The following is a description of a gene set: studied in species Homo sapiens Human Gene Set: GSE21033_1H_VS_12H_POLYIC_STIM_DC_UP BACKGROUND: Dendritic cells (DC) play a central role in primary immune responses and become potent stimulators of the adaptive immune response after undergoing the critical process of maturation. Understanding the dynamics of DC maturation would provide key insights into this important process. Time course microarray experiments can provide unique insights into DC maturation dynamics. Replicate experiments are necessary to address the issues of experimental and biological variability. Statistical methods and averaging are often used to identify significant signals. Here a novel strategy for filtering of replicate time course microarray data, which identifies consistent signals between the replicates, is presented and applied to a DC time course microarray experiment. RESULTS: The temporal dynamics of DC maturation were studied by stimulating DC with poly(I:C) and following gene expression at 5 time points from 1 to 24 hours. The novel filtering strategy uses standard statistical and fold change techniques, along with the consistency of replicate temporal profiles, to identify those differentially expressed genes that were consistent in two biological replicate experiments. To address the issue of cluster reproducibility a consensus clustering method, which identifies clusters of genes whose expression varies consistently between replicates, was also developed and applied. Analysis of the resulting clusters revealed many known and novel characteristics of DC maturation, such as the up-regulation of specific immune response pathways. Intriguingly, more genes were down-regulated than up-regulated. Results identify a more comprehensive program of down-regulation, including many genes involved in protein synthesis, metabolism, and housekeeping needed for maintenance of cellular integrity and metabolism. CONCLUSIONS: The new filtering strategy emphasizes the importance of consistent and reproducible results when analyzing microarray data and utilizes consistency between replicate experiments as a criterion in both feature selection and clustering, without averaging or otherwise combining replicate data. Observation of a significant down-regulation program during DC maturation indicates that DC are preparing for cell death and provides a path to better understand the process. This new filtering strategy can be adapted for use in analyzing other large-scale time course data sets with replicates. Genes up-regulated in bone marrow-derived dendritic cellstreated by poly(IC): 1h versus 12h. from publication Olex AL, Hiltbold EM, Leng X, Fetrow JS (PMID 20682054), and this is the list of marker genes: TLE6, IGF1R, TTPAL, MAP3K1, TUBE1, C2CD2L, ARID2, TAPT1, PCYT1A, CDCA7, SPO11, CAMKK1, URB2, MPP1, OTUD1, TCOF1, RGS10, CYFIP2, DUSP16, ODF4, CNN3, ID3, ANXA5, TSC22D1, VPS26B, CACNB1, SOCS1, SLC37A2, JUP, NFKB2, SCN4B, PPM1H, SLC9A7, CDH24, MAFB, ENDOU, OLIG3, COLQ, PER1, PYCARD, BTG2, ADAMTS17 (NCBI Gene Id 170691), STAMBPL1, SPATA31F3, NR4A1, TUBB2B, ITPKB, PDPK1, ENTPD5 (NCBI Gene Id 957), PHRF1, ZCCHC12, SEMA4D, PRRT1, LIG4, PTP4A3, NCOA6, FLVCR1, FAM161B, ITIH5, RNF169, DUSP5, MTG2, USP42, DOT1L, SLC25A35, ARHGAP31, ANO6, CBFA2T3, VARS2, DCLK2, CEP295NL, HDAC7, DCLRE1C, SESN2, MGAT1, RAMP1, RALGDS (NCBI Gene Id 95849), CBL, UCK2, ITGA6, ABCB9, UNC5CL, RORC, NFATC3 (nuclear factor of activated T cells 3), SYT14, F13A1, TMC8, RGS14 (regulator of G protein signaling 14), FHIP2A, SPINT2, FBXL14, TMEM184B, PPP1R14B, VAMP1, UTP25, EXOC2, TOLLIP, PARP11, DGKD, AGTRAP, RASGRP1, AGBL5, DESI1 (desumoylating isopeptidase 1), MBNL1, RNF40, SIT1, GLCCI1, TBC1D2B, FMNL2, EZR, GATA3 (GATA binding protein 3), PPT1, REC8, MPRIP, XRRA1, CD247, CAMKV, RRAGD, USP7, RPRD1B, C1GALT1, DCK, MAP4K5, PTPRF (protein tyrosine phosphatase receptor type F), ARL5C, TSPAN18, JADE1, SMOC1 (NCBI Gene Id 64093), MYB (MYB proto-oncogene, transcription factor), LENG1, DNAJC6, MAGI3, AHDC1, HELZ (helicase with zinc finger), PAN3, SPEN, PLEKHF2, ANKS1A, KMO, XKRX, GBP4, NTRK3, RNF157, ZEB1, SEMA7A, PSD3, OLFML3, SLA, EAF1, CYP11B1, MMP17, MBNL2, ERRFI1, EIF2AK3, PIK3R5, SCRIB, ATL1, P2RX1, XBP1, PPP1R16B, NRIP1, EDEM1, NFATC2, CSGALNACT1, TACC2, H6PD, MATN2, LCA5, KHDRBS1, CLDN4, CEP120, AKT1, PTMS, PPP1R3B, MAP3K8, PFKFB3